The following is a description of a gene set: species: Homo sapiens Human Gene Set: HP_PROTRUSIO_ACETABULI Protrusio acetabuli Intrapelvic bulging of the medial acetabular wall., and this is the list of marker genes: CRTAP, MMP2, SERPINF1, TGFBR2, BMP4 (NCBI Gene Id 652), PLOD1, SMAD3, HSPG2, FKBP10, FBN1, COL1A1, COL1A2, TGFB2